Given this list of marker genes Slc26a1, Slc26a9, Slc5a12, Slc26a4, Slc26a7, Slc26a6, Slc26a11, Slc26a2, Slc26a3, here is a description of the gene set: Multifunctional anion exchangers Mouse Gene Set: REACTOME_MULTIFUNCTIONAL_ANION_EXCHANGERS studied in species Mus musculus